The following is a description of a gene set: Human Gene Set: MIR6768_3P species: Homo sapiens Genes predicted to be targets of miRBase v22 microRNA hsa-miR-6768-3p in miRDB v6.0 with MirTarget v4 prediction scores > 80 (high confidence targets). from publication Chen Y, Wang X (PMID 31504780), and this is the list of marker genes: DCBLD2, ZNF470 (NCBI Gene Id 388566), CASK, AGO3, ZDHHC23, STOX2, MEX3B, ZNF546, NUP58, RPS6KB1, MMP8, MRTFB, PLEKHA2, SLC26A7, RSC1A1, RNF212B, PIK3R1, GLUD1, KCNQ3, DAGLA, ENAH, MRPS6, WTAP, PTPN20, NFIB, ZNF107, DIP2B, ADIPOR2, GTF2IRD1, PRTG, NEO1, FOXF1, FOXD4L3, CCDC71L, DNAJC6, PTBP3, FNDC7, CDC42SE2, TAL1, EIF4A2 (NCBI Gene Id 63124), SEH1L (NCBI Gene Id 81929), FOXD4L6, USP37, ESYT1, CNOT4, LRP1B (NCBI Gene Id 55424), ZNF189, IDH3A, REEP1, ARPC3, PHC3, HDAC2, PRRC2B, KDM3B, FAM98A, RRAGA, ZDHHC15, SEPTIN9, EBF1, EVC, GRPEL2 (NCBI Gene Id 134266), SLC25A36, PTBP2, ANLN, MAPRE1, BHLHE40, LHX6, SYNJ2BP, SACM1L, ZBTB41, LIMA1, FSD1L, RAB31, PDIA6, DHX15, THAP4, OPRM1, AIP, TMEM151B, IQCE (IQ motif containing E), PPP1R12A, COL4A1, LLPH (LLP homolog, long-term synaptic facilitation factor), UBE2E3, MFSD14A, MPZL1, CCN2, RAB21, MEX3C, PBRM1, CLEC9A, SNX30, CMKLR1, TEAD1, NOC3L, OTUD4, CEP170, MBNL3, VPS52, PTPRG, GNAQ, SERINC5, ZNF781, CCDC14, GOSR2, WDFY3, POLR1C, N4BP2, DAG1, USP15, RFC1, HECTD2, XYLT1, CAMSAP2, RBM47, ZNF117, RFX2, OSBPL8, CDC5L, ERN1, SP1, MED13L, IGF2R, RAPGEF2, IVD, CARMIL1, JRK, STC1, CDC42BPB, SIX4, ZNF737, RHOBTB1, PPP3CA, TCF12, GATA6, ZNF763, PIK3C2A, RHOA, INSYN2A, ZBTB44